The following is a description of a gene set: Mouse genes annotated to increased B cell derived lymphoma incidence (MP:0002023) retrieved from the Mouse Genome Informatics database via MouseMine studied in species Mus musculus from publication Motenko H, Neuhauser SB, O'Keefe M, Richardson JE (PMID 26092688) Mouse Gene Set: MP_INCREASED_B_CELL_DERIVED_LYMPHOMA_INCIDENCE, and this is the list of marker genes: Dkc1, Prdx1, Ung, Mtss1, Rassf1, Ikzf3, Bub1b (BUB1B, mitotic checkpoint serine/threonine kinase), Cdkn1a, Suv39h2, Piga, Fen1, Fdxr, Uimc1, Suv39h1, Eaf2, Nbn, Mir125b-1, Trp53, Mlh1, Tbrg1, Bad, Inpp5d, Rassf5, Npm1, Cdkn2a, Ptpn11 (protein tyrosine phosphatase, non-receptor type 11), Ssbp2, Mus81 (MUS81 structure-specific endonuclease subunit), Cdkn2c, Prdm2, Ncoa3, Ezh2, Becn1, Hmga1, Flt3, Pdcd4, Polg, Smurf2, Smg1, Mtus1, Aire, Myc, Fhit, Hephl1, Pml, S1pr2, Bcl2, Mir155, Pcbp4, Sirt2, Eif4e, Wwox, Prf1, Mir146, Mef2b, Ing1, Mdm2, Pms2, Nabp2, Cop1, Tnk1, Skil